The following is a description of a gene set: The chemical reactions and pathways resulting in the breakdown of D-glucuronate into D-xylulose 5-phosphate. species: Mus musculus Mouse Gene Set: GOBP_D_GLUCURONATE_CATABOLIC_PROCESS_TO_D_XYLULOSE_5_PHOSPHATE, and this is the list of marker genes: Cryl1, Akr1a1, Dcxr, Sord, Xylb